Given this list of marker genes NINL, CEP70, TUBB, CKAP5, CLASP1, AJUBA, SSNA1, UBC, DYNC1H1, TUBB4B (NCBI Gene Id 10383), CCP110, YWHAE, BTRC, HAUS2, CEP192, SKP1, AKAP9, CNTRL, HAUS1, HSP90AA1, MAPRE1, PPP1R12B, DCTN2, CEP63, CETN2, DYNLL1, CENPJ, CEP76, CEP43, CCNB2, DYNC1I2, CSNK1D, HAUS8, TUBG1, TUBA4A, CEP152, HAUS4, CDK5RAP2, CEP131, OPTN, PRKAR2B, HAUS5, CEP57, AURKA, BORA, CUL1 (NCBI Gene Id 8454), TUBA1A, FBXW11, HAUS6, RAB8A, NDE1, PLK4, PLK1, PRKACA, YWHAG, SDCCAG8, CSNK1E, UBB, CCNB1 (cyclin B1), PAFAH1B1, CEP78, PPP2R1A, CEP164, TUBB4A, OFD1, HAUS7, DCTN3, ACTR1A, DCTN1, PPP1R12A, HAUS3, RPS27A, CDK1, ODF2, PCNT (NCBI Gene Id 9346), SFI1 (SFI1 centrin binding protein), PPP1CB, NEK2, CEP135, ALMS1, CEP72, CEP250, PCM1, UBA52, CEP41, CEP290, NEDD1, here is a description of the gene set: Human Gene Set: REACTOME_REGULATION_OF_PLK1_ACTIVITY_AT_G2_M_TRANSITION studied in species Homo sapiens Regulation of PLK1 Activity at G2/M Transition